The following is a description of a gene set: electronically inferred by orthology from the curated human pathway This event has been computationally inferred from an event that has been demonstrated in another species.<p>The inference is based on the homology mapping from PANTHER. Briefly, reactions for which all involved PhysicalEntities (in input, output and catalyst) have a mapped orthologue/paralogue (for complexes at least 75% of components must have a mapping) are inferred to the other species. species: Mus musculus part of: Hemostasis Reactome Pathway: Cell surface interactions at the vascular wall, and this is the list of marker genes: Atp1b2, Hras, Itgal, Pf4, Bsg (NCBI Gene Id 12215), Yes1, Cd74, Itgax, Grb2, Slc16a3 (NCBI Gene Id 80879), Angpt2, Slc7a9, Fyn, Atp1b1, Itgb2, Slc7a7, Ppia, Pik3cb, Pros1, Mag, Gas6, Proc, Apob, Ppil2, Jaml, Shc1, Itga4 (NCBI Gene Id 16401), Atp1b3, Epcam, F2, Lck, Igll1, Pik3r2 (NCBI Gene Id 18709), Spn, Esam, Slc16a8, Fcamr, Dok2, Cd177, Slc7a10, Glg1 (golgi apparatus protein 1), Slc3a2, Trem1, Slc7a8, Ceacam1, Ptpn6, Sele (NCBI Gene Id 20339), Mif, Angpt4, Itga5, Mertk, Slc7a6, Itga3, Cav1, Selp